The following is a description of a gene set: Unilateral cryptorchidism Human Gene Set: HP_UNILATERAL_CRYPTORCHIDISM studied in species Homo sapiens Absence of a testis from the scrotum on one side owing to failure of the testis or testes to descend through the inguinal canal to the scrotum., and this is the list of marker genes: IGF2, XYLT2, SRY, NFIB, HOXC13, ADARB1, INSL3, DDX59, SMOC1, KMT5B, MYRF, RNF135, TSR2, SIN3A, NFIX